Given this list of marker genes Cysltr1, Gpr17, Ltb4r1, Cysltr2, here is a description of the gene set: electronically inferred by orthology from the curated human pathway Reactome Pathway: Leukotriene receptors studied in species Mus musculus This event has been computationally inferred from an event that has been demonstrated in another species.<p>The inference is based on the homology mapping from PANTHER. Briefly, reactions for which all involved PhysicalEntities (in input, output and catalyst) have a mapped orthologue/paralogue (for complexes at least 75% of components must have a mapping) are inferred to the other species. part of: Eicosanoid ligand-binding receptors